Given this list of marker genes KLRC2 (NCBI Gene Id 3822), KLRD1, LAMP1, RAET1E, STAT5A (signal transducer and activator of transcription 5A), NECTIN2, NCR3, IL18RAP, SLAMF6, KLRC4-KLRK1, CD226, SH2D1A, KLRC3, PVR, KLRC4, KLRK1, HLA-F, HLA-E, IL21, CD160, VAV1, CADM1, STAT5B, IL12B, IL12A, CRTAM, RASGRP1, KLRC1, AP1G1, LAG3 (NCBI Gene Id 3902), here is a description of the gene set: studied in species Homo sapiens Any process that activates or increases the frequency, rate or extent of natural killer cell mediated cytotoxicity. Human Gene Set: GOBP_POSITIVE_REGULATION_OF_NATURAL_KILLER_CELL_MEDIATED_CYTOTOXICITY